The following is a description of a gene set: Regulation of insulin secretion Human Gene Set: REACTOME_REGULATION_OF_INSULIN_SECRETION species: Homo sapiens, and this is the list of marker genes: GNA11, GCG, STXBP1, KCNC2, VAMP2, SLC2A1, KCNG2 (NCBI Gene Id 26251), GNB5, ADRA2A, GNB4, SYT5, GNB2, ADCY8, GNA14, GNG4, ADCY6, AKAP5, GNG10, ACSL4, GNGT2, CACNA1C, ITPR3, GNG2, PRKAR2B, GNB1 (NCBI Gene Id 87729), ITPR1 (inositol 1,4,5-trisphosphate receptor type 1), GNG7 (NCBI Gene Id 90274), ADCY5, PRKACB, PLCB3, GNAI2, RAPGEF3, PLCB2, GNG3, KCNS3, GNG12, KCNB1, GNA15, CACNA1D, CD36, SNAP25, INS, PRKAR2A, PRKCA, MARCKS, PRKACG, CACNA2D2, GNB3, ACSL3, PRKAR1A, CACNB2, RAP1A, SLC2A2, PRKACA, CACNA1E, FFAR1, CACNA1A, PLCB1, CACNB3, IQGAP1, GNG8, GNG13, GLP1R, RAPGEF4, GNAQ, ITPR2, CHRM3, AHCYL1, ABCC8, ADRA2C, STX1A, KCNJ11, PRKAR1B, GNG11, GNGT1, GNAI1, GNG5, GNAS (GNAS complex locus)